The following is a description of a gene set: Human Gene Set: GOCC_ACTOMYOSIN Any complex of actin, myosin, and accessory proteins. species: Homo sapiens, and this is the list of marker genes: FSCN1, BAG3, PALLD, LIMCH1, CYBA (NCBI Gene Id 1535), EVL, ACTA1, XIRP2, SHROOM4, MYH6, MST1R, ZYX, SEPTIN11, MYLK, PPP1R12C, SIPA1L3, CNN2, ACTN4, PGM5, MYH14, GAS2L2, CALD1, CORO1B, FHOD1, CDC42BPA, PDCD6IP, RAI14, ABLIM1, FBLIM1, FLNB, FAM107A, SPEF1, PDLIM3, FERMT2, DIXDC1 (NCBI Gene Id 85458), SORBS1, LDB3, SEPTIN12, TLNRD1, PDLIM5, MYO1C, DBN1, LUZP1, MYH7, ROR1, ACTN1, ABLIM3, AFAP1L1, VANGL2, CDC42BPB, MYL9, SEPTIN9, SYNPO, TRIP6 (thyroid hormone receptor interactor 6), MICALL2, GAS2, STX1A, LIMA1, KAT2B, PPP1R12A, PXN, ASB2, GAS2L1, PDLIM7, CTTNBP2NL, SEPTIN7, PDLIM2, TEK, AFAP1, FHL3, DST, TPM1, DAAM1, DCTN4, PDLIM4, MYH9, LPP, SH2B2, SYNPO2, BLOC1S6, ACTA2, AMOT, PPP1R12B, NEBL, XIRP1, PTK2, PRICKLE4, MYH10, TPM4, LCP1, MYO18A, MYL12B, TPM3, PDLIM1 (PDZ and LIM domain 1)